Given this list of marker genes Tsen54, Rpp38, Tsen2, Prorp, Dicer1, Ago3, Pop7, Trmt10c, Pop4, Clp1, Dhx9, Hsd17b10, Rpp40, Ago4, Rpp30 (NCBI Gene Id 54671), Dgcr8, Eme2, Mir28a, Mus81, Eme1, Rad51c, Tsnax, Wdr18, Tsen34, Tsn, Rpp25l, Ago1, Pop1, Tarbp2, Rpp21, Ago2, Drosha, Mir27a, Prkra, Slx4, Las1l, Pop5, Rag1, Rpp14, Rpp25, here is a description of the gene set: A protein complex which is capable of endonuclease activity. species: Mus musculus Mouse Gene Set: GOCC_ENDONUCLEASE_COMPLEX